The following is a description of a gene set: Mouse Gene Set: MIR_6986_5P studied in species Mus musculus Genes predicted to be targets of miRBase v22 microRNA mmu_miR_6986_5p in miRDB v6.0 with MirTarget v4 prediction scores > 80 (high confidence targets). from publication Chen Y, Wang X (PMID 31504780), and this is the list of marker genes: Hs6st1, Iqsec3, Gng11, Zfp446, Wdtc1, Lrrc32 (leucine rich repeat containing 32), Ppp1r16b, Tmppe, Zbtb4, Kdm2a, Limk1, Gdpd4, Car8, Bahd1, Ptpa, Dusp8, Kif2c, Hectd3, Xrcc2, Lfng, Scamp5, Camk1d, Cacna1h, Cdh4, Spryd3, Fxn, Myrf, Cplx2, Col1a1, Bbs1, Fscn1, Rad54b, Tlcd3b, Gnai2, Ubl7, Jak3, Ctdsp1, Tnf, AW554918, Rbm28, Ntrk3, Chodl, Nherf2, Tmem98, Ccdc97, Kif1a, Insl3, Sh3pxd2a, Vamp2, Foxp4, Onecut2, Nfic, Fads1, Gng7, Igf2, Clstn1, Snx17, Ppt2 (NCBI Gene Id 71666), Slc24a3, Klhdc10, Ttyh3, Stim1, Cyp8b1, Map1a, Ttc7, Cdc42ep2, Kdm6b, Wdr81, Gatad2a, Ccdc121rt1